The following is a description of a gene set: Genes having at least one occurence of the motif TCTGATC in their 3' untranslated region. The motif represents putative target (that is, seed match) of human mature miRNA hsa-miR-383 (v7.1 miRBase). Human Gene Set: TCTGATC_MIR383 studied in species Homo sapiens, and this is the list of marker genes: ZNF654, NUP153, BLOC1S6, SORCS1, RBM26, TAOK3, MAPKAP1, DIO1, SHMT2, UGGT1, ACACA, MAL2, CD47, EPAS1, BRCC3, GABRB3, CNIH1, NEUROD1, PCDH17, ZFHX3, SLC2A6, SP7, RAB8A, HNRNPH2, STRN3, RBMS1, IDI2-AS1, SRSF5, DCLK1, NXPH1, CTNNAL1, HNRNPA1, UBE2R2, LIN28A, RBM3, IVNS1ABP, ARID2, GADD45G, SAMD4B, FOXN3, ZNF410, MSL2, EYA3, ANKRD11, CLEC3A, SOX5, IRF1, COL4A3, SLC2A13, VEGFA